The following is a description of a gene set: studied in species Homo sapiens from publication El Kasmi KC, Holst J, Coffre M, Mielke L, de Pauw A, Lhocine N, Smith AM, Rutschman R, Kaushal D, Shen Y, Suda T, Donnelly RP, Myers MG Jr, Alexander W, Vignali DA, Watowich SS, Ernst M, Hilton DJ, Murray PJ (PMID 17114459) Human Gene Set: GSE5589_WT_VS_IL6_KO_LPS_STIM_MACROPHAGE_45MIN_DN IL-10 or IL-6 stimulation of control 129xC57BL/6 murine bone marrow derived macrophages in the presence of LPS. We used microarrays to detail the global programme of gene expression changes in response to IL-6 or IL-10 stimulation in the presence of lipopolysaccharide. BMDMs were isolated from control, IL-6-/-, and IL-10-/- mice on a 129XBL/6 mixed background mice and differentiated in the presence of CSF-1 for 6-7 days. Cells were scraped and plated in 6 well plates at 2x10e6/well. Cells were washed with complete DMEM and rested for 1-2 hr before stimulation with combinations of IL-10 (10 ng/ml), IL-6 (2 ng/ml) or LPS (100 ng/ml) for 45 min or 180 mins. Complete biological replicates were performed. Genes down-regulated in bone marrow-derived macrophages at 45 min stimulation by LPS: wildtype versus IL6 knockout., and this is the list of marker genes: ZBED3, LDLRAP1, WFS1, RSPO1, CLDND1, CYB5R2, VWF, PTPRE, UROC1, B3GALT6, MMP8, TBXA2R, DPYS, LGALS2, CYP1B1, HM13, GHDC, CA7, SIAH2, ORAI1, YWHAE, NFE2L2, RNF126, OXCT1, IL18BP, RFX1, PSMG4, SEL1L3, RNF32, LYZL4, PPP1R3C, SPNS2, TTC7B, NOL3, FGL2, CCNQ, DOT1L, SYT11, CCK, SMAD7, SH3PXD2B, DNAJC27, KCNQ1, FAM98C, ABCC1, VARS1, CDC42SE2, CDCP1, TSPAN13, GOT1, RNF41, GNA15, ST3GAL1, RNF24, FXYD2, SPINT1, MARCHF1, PATL2, SLC12A5, LRBA, CRACDL, IFFO2, FAAP24, ITGAX, PENK, GET3, BSG, E2F8, RTN4RL1, GLCCI1, MMP9, TRAF3, H1-10, GPALPP1, BLCAP, ACOT11, LEMD2 (LEM domain nuclear envelope protein 2), SCO1, NT5M, INTS9, MN1 (MN1 proto-oncogene, transcriptional regulator), SNAPC2, UBE2F, C2orf88, DOK2, SPINT2, NCS1, CCND3, P3H1, SDC2, MBD2, CFAP54, ST3GAL5, RPS6KA3, SF3A2, ADAM15, AMN1, CPNE2, PLAUR, CNNM2, SLC12A4 (solute carrier family 12 member 4), RNF14, LIMK1, ZNF516, PTPN9, RNF128, DAB2IP, ANXA11, AHR, PLBD1, LONRF3, PSMB10, CLCA2, TMEM222, GKN2, CD163, IQCB1, PDGFA, TTL, JUND, MAP2K4, RHBDF1, SAV1, P3H3, CNNM4, RPS6KC1, RIPOR1, RBM15B, NUCB1, IL21R, SOCS6, UBE2E3, FAM118A, MCF2L, RHOJ, OSBPL1A, MGMT, MAFK, ACOT1, PMEPA1, FAM86B2 (family with sequence similarity 86 member B2), B3GLCT, OSM (oncostatin M), CSF2RA (NCBI Gene Id 8282), E2F3, RYR1, ACYP2, SOX9, PEX26, MYADM (NCBI Gene Id 91663), IL3RA, IRF4, ZYX, ARFIP2, LPCAT1, FOXRED2, GPAT2, PFDN4, SATB1, TOM1L1, NAGPA, RUSC2, CEP170B, TMEM217, SRPRA, BTRC, FBXO38, DOCK2, PPARG, TRIP6, GCLM, KCNS1, POU6F2 (NCBI Gene Id 7968), FLYWCH2, SMDT1, YIF1B (NCBI Gene Id 90522), SUMO3, ZNF219, DCSTAMP, PDIA3, NCDN (NCBI Gene Id 23154), TRAF5, RGS14, HGSNAT, CCL4, TMEM178A, BCL7B, SIKE1, RTKN, PTGS1, SLC1A3, USPL1, RETSAT, ARHGAP6, STXBP1, MYO1B, PLA2G7, GEMIN5, ALKBH2, CCL24